The following is a description of a gene set: studied in species Mus musculus Any process that modulates the frequency, rate or extent of protein localization to cilium. Mouse Gene Set: GOBP_REGULATION_OF_PROTEIN_LOCALIZATION_TO_CILIUM, and this is the list of marker genes: Entr1, Gsk3b, Ccdc88a, Efcab7, Gdi2, Lztfl1, Crocc, Dzip1 (NCBI Gene Id 67061), Gas8, Ccdc66, Inpp5e